The following is a description of a gene set: Genes down-regulated in comparison of dendritic cells (DC) stimulated with LPS (TLR4 agonist) at 16 h versus DC cells stimulated with Gardiquimod (TLR7 agonist) at 16 h. Human Gene Set: GSE17721_LPS_VS_GARDIQUIMOD_16H_BMDC_DN studied in species Homo sapiens from publication Amit I, Garber M, Chevrier N, Leite AP, Donner Y, Eisenhaure T, Guttman M, Grenier JK, Li W, Zuk O, Schubert LA, Birditt B, Shay T, Goren A, Zhang X, Smith Z, Deering R, McDonald RC, Cabili M, Bernstein BE, Rinn JL, Meissner A, Root DE, Hacohen N, Regev A (PMID 19729616) mouse primary BMDCs were stimulated with tlr ligands and gene expression changes were profiled on Affymetrix arrays, and this is the list of marker genes: TMBIM1, CKMT2, TXNRD1, TLE4, MLEC, PRKCB, NEDD4, BTG2, NHLH1 (NCBI Gene Id 93188), DBT, MMUT, IARS1, NUCKS1, DHRS3, SCD, UBE2J1, LIMD2, MTG2, PABPC4, MAP1LC3A, PTPRJ, CKLF (chemokine like factor), METTL1, UXS1, SLF1, RPS16, HSP90B1, STK10, BAP1, RPLP2, ARHGAP12, HGSNAT, DVL1, FN1 (NCBI Gene Id 2335), THUMPD1, CNIH1, TAL1, PRNP, RILPL2, DNAJB5, CERS5 (ceramide synthase 5), TRAPPC5, SRSF11, H1-8, LAMTOR4 (NCBI Gene Id 392758), ACBD6, TXNIP, MBOAT7, ACTG2, SLF2, KLF9, HSD11B1, GCLM, FGD4, PGM2, AEN, TRAPPC2, SERPINB5, SNX12, GNG10, RNF128, ABCB4, PSMD2, KCNK13, TMEM135, STK17B, PCBD2, YWHAG, PEA15 (proliferation and apoptosis adaptor protein 15), FAM98A, EMC2, CLDN11, POFUT2, AAMP, ZNF334, BET1, CRIM1, COPS3, TBRG4, RAB6A (RAB6A, member RAS oncogene family), RPL7A, SLC30A5, CXCL3, IRAK4, TMED7, EDEM3, EMP3, AKR1B15, XYLT2, EEF1G, MFSD10, HS6ST3, IDH3G, ZBTB33, MPO, WASF2, GLCE, CLEC7A, VWA8, TRIB1, TRAM1, USP20, NCOR2, IFTAP, RAB38 (RAB38, member RAS oncogene family), RPL38, UBALD2, PTGS1, IFNG, IQGAP3, UTP18 (NCBI Gene Id 51096), CYRIB, MECR, CALU (calumenin), PRXL2B, RPL3, HDLBP, DAP, P2RY6 (pyrimidinergic receptor P2Y6), MED23, ADGRF1, ATP6V0B, DYNLT3, SERPINB1, HSD17B12, FKBP11, CD72, ACACA, PUF60, POLR1E, ARL10, ATP2A2, RRP15, FUOM, EIF2S3, ARHGAP21, OPN3, REEP5, LIMD1, PI4KA, EMG1, GLIPR1, CHMP4C, INA, GNG2, SREBF2, EPHA7, TMEM119, FES, AHNAK, PRKCH, SNRPB2, AKR1E2, NEK9, PAFAH2, ZNF7, HLCS, E2F6, CD300C, TMX1, PRKAR1A, RPL31, MMP8, EFS, HJURP, ADAMTS1, QNG1, OTUD6B, CMTM3, VASP, CD300LD, RPAP2, FIGN, SLC44A1, NUDCD2, MRAS, KCTD12, TBC1D23, S100A6, PSEN2, CCR2, ABCC3, GSS, ATP1A3, SMN1, KIF20A, RAB31, STARD7, ARIH2, STMN1, ANXA5, MAP4K5, ADH5, MARCHF6, NCKAP5L, ZC3H12A (zinc finger CCCH-type containing 12A), ID3, RAN, GUSB, MEF2A